The following is a description of a gene set: studied in species Mus musculus Mouse Gene Set: GOBP_NEGATIVE_REGULATION_OF_PROTEASOMAL_PROTEIN_CATABOLIC_PROCESS Any process that stops, prevents or reduces the frequency, rate or extent of proteasomal protein catabolic process., and this is the list of marker genes: Wac, Csnk2b, Hsp90ab1, Ubxn2a, Usp9x, Caml, Lamp3, Ophn1, Tlk2, Phf20l1 (PHD finger protein 20-like 1), Sco1, Trim39, Usp7, Usp25, Prkcg, Psme3ip1, Sgta, Aqp11, Rybp-ps, Hfe, Shh, F8a, Map1a, Bag5, Rybp, Styx-ps, Gabarapl2, Bag6, Marchf7, Uchl5, Usp26, Ccar2, Gipc1, Taf9, Usp14, Svip, Pabpn1l, Mtm1, Smarcc1, Pbk, Nop53 (NCBI Gene Id 98700), Park7, Csnk2a2, N4bp1, Ubxn1, Alad, Usp38, Eif3h, Psmf1 (NCBI Gene Id 99294), Usp19, Ttc36, Klhl40, Ogt, Senp1, Fhit (NCBI Gene Id 14198), Styx, Rpl11, Ddrgk1, Clec16a